Given this list of marker genes COMMD3, EI24, SLBP, NUP205, DHX8, HDDC2, COMMD6, PSMD2 (NCBI Gene Id 5708), PSMA6, RFC3, ARPC5, MYC, EVL, FAM111A, BCL2L13, S100A10, CD3G, PRDX4, C1GALT1C1, SPC25, MCM3, TTC1, ALG5, EXOSC8, RUVBL1, CHEK1, PID1, PSMA2, UBR7, WDR11, PITPNA, PUDP, POLR2D, ACTG1, MRPL15, MAD2L1, UBE2N, ATP5F1A, DDX1, UTP6, LIG1 (NCBI Gene Id 3978), BUB1B (NCBI Gene Id 701), SGK3, NFX1, PALLD, TRIT1, RPL28, SLC25A32, SMARCAL1, TMBIM4, RCC1L, PSMB1, TPM3, MRPL39, SARS1, PLCL2, ANAPC1, ODC1, DSN1, IP6K2, MTMR4, HSP90AB1, NPEPPS, FDFT1, CAPN2, ATP5PB, SINHCAF, RCOR2, P4HB, TFB2M, COQ2, ANGPTL1, PRC1, ARL5A, SNX5, NARS2, CTPS1, STX7, STAT3, PRNP, STIL, NAA20, FBXL9P, MDH1, DLGAP5, MACROH2A1, GNB1, RRM1, MT-ND3, LYRM4, HIBADH, GNAI3, UBA2, ARCN1, MNS1, MCM7, SNX1, SYCE2, HNRNPF, HPGDS, PA2G4, TMA7, EXOC8, ELP2, CDC26, MYOT (myotilin), TGFBR1, OSGEP, CBX1, TMX2, MCM6, SFT2D2, ACOX1, CD99L2, CALR, MTA2, CALM1, RPL4, RC3H2, PRMT3, STRAP, GHITM, ZCCHC17, ALYREF, HSD17B4, ACOT13, NDFIP1, CD2BP2, FBH1, ERH, ANP32E (acidic nuclear phosphoprotein 32 family member E), SEPTIN11, GINS4, SPACA1, ARL6IP1, DHX29 (NCBI Gene Id 94080), EIF3J, CPSF3, ADH5, POLE2, BTBD1, CTR9, GLIPR2, SSRP1, RRN3, CDK2, JKAMP, ARF4, CAPZB, NUP93, PRDX3, HDAC2, CHST10, GOSR2, CDC42, TOP2A, TRAF6, THYN1, NDE1, ZDHHC2 (zinc finger DHHC-type palmitoyltransferase 2), KARS1, PPP1CC (protein phosphatase 1 catalytic subunit gamma), PPP2R5C, RRAS2, NFKB1, here is a description of the gene set: We identified Pparg as a major orchestrator of the phenotype of adipose-tissue resident regulatory T cells (VAT Tregs). To establish the role of Pparg in shaping the VAT Tregs gene profile and cell dynamics, Tregs from lymph nodes and visceral adipose tissue of mice sufficient and deficient of Pparg expression in Tregs were double sorted for microarray analysis. species: Homo sapiens Genes up-regulated in T conv cells from aged PPARG knockout: visceral adipose tissue versus lymph node. from publication Cipolletta D, Feuerer M, Li A, Kamei N, Lee J, Shoelson SE, Benoist C, Mathis D (PMID 22722857) Human Gene Set: GSE37532_VISCERAL_ADIPOSE_TISSUE_VS_LN_DERIVED_PPARG_KO_TCONV_CD4_TCELL_UP